The following is a description of a gene set: Any process that activates or increases the frequency, rate or extent of cellular response to insulin stimulus. Mouse Gene Set: GOBP_POSITIVE_REGULATION_OF_CELLULAR_RESPONSE_TO_INSULIN_STIMULUS studied in species Mus musculus, and this is the list of marker genes: Prkcz, Nr1h4, Nucks1, Mfn2, Ctsd, Zbtb7b, Sorbs1, Erfe, Gnai2, Myo5a, Gkap1, Echdc3, Sorl1, Ptpn2, Igf2, Opa1, C1qtnf9 (C1q and tumor necrosis factor related protein 9), Ptpn1, Osbpl8, Lep, Marcks, Ptpn11 (NCBI Gene Id 72646), Tsc2, Ide (NCBI Gene Id 73765), Serpina12 (serine (or cysteine) peptidase inhibitor, clade A (alpha-1 antiproteinase, antitrypsin), member 12), Ins1, Myo1c, Snx5, C1qtnf12, Adipor1, Ins2, Pak1, Irs1, Agt, Sirt1, Esrra, Src